The following is a description of a gene set: Mouse Gene Set: REACTOME_RUNX3_REGULATES_YAP1_MEDIATED_TRANSCRIPTION species: Mus musculus RUNX3 regulates YAP1-mediated transcription, and this is the list of marker genes: Tead2, Runx3, Tead4, Yap1 (NCBI Gene Id 22601), Tead3, Tead1